The following is a description of a gene set: species: Homo sapiens Human Gene Set: GOBP_POSITIVE_REGULATION_OF_IMMUNE_RESPONSE Any process that activates or increases the frequency, rate or extent of the immune response, the immunological reaction of an organism to an immunogenic stimulus., and this is the list of marker genes: PLCG1 (NCBI Gene Id 5335), KLRD1, PCK1, RELA (NCBI Gene Id 5970), IGHA2, FCGR1A, FLOT2, HSPA1A, GCSAM, USP27X, YWHAE, MATR3, IRF3, VTCN1, C1QC, CLPB, LAG3, C1QB, CD74, UNC93B1 (NCBI Gene Id 81622), PYDC1, RBCK1, KLRK1, TNIP2, ITPRIPL1, XIAP (NCBI Gene Id 8257), POLR3B, FCGR2B, GDI1, TGFB1, DHX33, TRIM3, FCN3 (ficolin 3), IL1B, GPR32P1, CCR7, BTN2A1, HCK (HCK proto-oncogene, Src family tyrosine kinase), ZP3 (NCBI Gene Id 7785), IPO5, CD300LD, IFNK, TRIL, LAMP1, CLEC7A, ANXA1, RAP1A, MALT1, CD1A, PDE4B, DHX58, MFHAS1, CD5L, CD80, TREX1, ARID5A, ALPK1, TLR8, MICB, CYBA, SIRT1 (sirtuin 1), CBLB, C4BPB, STK11, SASH3, UBASH3A, HMGB2, FPR1, LYPLAL1, PLA2G6, KCNK6, PHB1 (prohibitin 1), MSH2, IRF4, CD22, TIFA, PTPRC, STOML2, BANK1, MASP2, PLCG2, ZCCHC3, PRAM1, RAB11FIP2, KLRC4-KLRK1, UBR2, GATA3, GPR108, PRNP (prion protein (Kanno blood group)), IL23R, PPP6C, TRAT1, BAX, PTPN2, HLA-DOB, IL27RA, CD4, CD59, MIR200B, FGR, IGHG2, GPR33, HLA-C, FPR3, LGR4, SLAMF6, IGHE, CFP, NLRP10, CLEC6A, ZDHHC9, GRB2, BTN2A2, RAB29, C4B, FLOT1, IL1R1, HRG, IL17F (interleukin 17F), DAB2IP, POLR3G, CD300LF, FBXL2, CCDC134, TRIM5, MAP3K7, TRIM31, SRC, TRIM41, TRAF2, GPR32, TEC, CRKL, ZDHHC5, PUM2, CPTP, B2M, C8A, TRIM6, ZDHHC4, SMPDL3A, FYB2 (FYN binding protein 2), SHB, PJA2 (NCBI Gene Id 9867), IL12B, FBXO38, PRKCE, RABGEF1, TRGC1, IRAK4 (NCBI Gene Id 95458), TLR6, NINJ1, PYDC2, HLA-H, C6, PTPN22, TSPAN6, KCNK13, BRD4, ABHD8, TIFAB, PTPN6, PSEN1, EIF2B1, NLRC3, ERBIN, BTK, WNK1, SPI1 (NCBI Gene Id 6688), LAPTM5, LETMD1, OPA1, BLK, HLA-DQB1, CREBBP, NAGLU, CD38, WDFY1, HSP90AA1, NONO (non-POU domain containing octamer binding), OAS3, AZGP1, FOXP3, IGHG4, NCKAP1L, PAK3, NOD1, C5AR1, MLH1, EIF2B2, RNF39, HLA-E, XCL1, VAV3, EIF2B5, FCHO1, PAWR, RBM47, NLRP3, TRBC1, APPL2, F2RL1, MAPK8, USP15, HRAS, HLA-DPB1, KMT5C, PYHIN1 (NCBI Gene Id 149628), PELI1, TLR7, BPIFB1, AKT1, RNF31, FCER1G, ACOD1, IGKC, BTNL3, STING1, SLC15A2, SLC39A6, NOP53, BTNL2, EXOSC6, LAX1, IGLC6, SKAP1, MEF2C, RC3H2, CTSG, MIR17, EP300, C4A, SHLD1, SCIMP, IGHA1, BTN3A2, TICAM2, SHLD3, LRCH4, AARS2, IFNL2, EREG, HLA-F, NLRC5, HMSD, RAET1G, TREML4, PSPC1, MIR4691 (NCBI Gene Id 100616403), POLR3F, GPLD1, KRT1, STAT5B, EIF2AK4, GRAMD4, CR1L, TARBP2, DDX60 (NCBI Gene Id 55601), TKFC, APPL1 (NCBI Gene Id 26060), RC3H1, THEMIS2, PLD2, SERPING1, SLC19A1, USP17L2, AP1G1, S100A8, TRGC2, RNF135, MARCHF5, A2M, ZBP1, ZC3H12A, MS4A1, CD1E, BIRC3, HHLA2, CD46, IKBKE, PIK3R1, BMX, KAT5, UBE2N, TIRAP, MIR149, MIR146A, OTUD4, IL12RB1, HLA-A, CACTIN, UFD1, CMKLR1, NFAM1, SLC11A1, C3AR1, FOSL2, IRAK2, PRKD2, KLRC4 (killer cell lectin like receptor C4), C2 (NCBI Gene Id 12263), LAMP2, CYRIB (NCBI Gene Id 51571), RIPK2, NOS2, FCER2, COLEC12, MYD88, RAET1L, TAP2, RBM14, NCR3, GBP1, RPS19, USP29, SLC39A10, PLEKHA1, TNFSF13, KARS1, BTN3A3, TLR3, JAK2, ADAM8, CD79B, CD8A, S100A9, CTSS, SLC22A13, HPX, TLR1, NFKBIL1, CD3G (NCBI Gene Id 917), CACNB3, HSPD1, CARD8, IFNL4, ADA (NCBI Gene Id 100), PTPRS, PPT1, BCL2, TAX1BP1, HDAC6, NLRP6, SEC14L1, ABHD17A, PARK7, LCK (NCBI Gene Id 95387), PTPRJ, RNF125, FYB1, HSPA8, HLA-B, LILRA4, LBP, PRKDC, PHPT1, CD1B, RASGRP4, NAIP, FFAR2, RNF185, MAPK1, CCL5, SQSTM1, IL17A, IL15, MNDA, TOMM70, TYK2, INPP5D, NOD2, CFH, ULBP3, ANKRD17, CASP6, UBE2K, MR1, IDO1, NLRC4, TNFSF4, CLNK, LIPA, PARP1, SLC46A2, PDPK1, CCR2, MASP1, TRBC2, HLA-DMA, IGLC7, ARRB2, MIR136, LGALS3, LIME1, CD1D, YES1, CD47, IFNL1, MIR18A, PRKCQ, CD300LB, RIGI, TRIM65, RNF34, DHX9, IFNG, LILRB4, PRKCB, HLA-DQA2, MMP12, NLRP2B, SYK, BTN1A1, S100A14, TMIGD3, PYCARD, COLEC10, CD79A, XBP1, NSD2 (NCBI Gene Id 7468), IRF7, STAP1, C3, BRAF (NCBI Gene Id 673), MIR21, C5AR2, RPS6KA3, IGHD, ELP6, C17orf99, CYLD, TRIM15, GPR65, CLU, ZNF683, CD8B, PCBP2, MIR140, IGLC3 (NCBI Gene Id 3539), LY96, REG3G, CARD11, MIR520E (microRNA 520e), C1R, ITGB2, GPS2, POLR3C (NCBI Gene Id 10623), LILRA2, PIK3CA, CFD, CASP1, NFKBIZ, GPATCH3, TXK, RTN4, MBL2, STMP1, TRDC, MAVS, TICAM1, UBQLN1, APP, FCMR, GPR31 (NCBI Gene Id 2853), PHB2, HMGB1, IL18RAP, SH2D1A, PQBP1, KLRC3, AP3B1, IL4R, IL2, ITCH, GBP2, TLR2, ULBP1, PLCL2, IL10, FZD5, PVRIG, TYRO3, CD55, ITK (IL2 inducible T cell kinase), TNFAIP3, C4BPA, HCFC2, SIN3A (NCBI Gene Id 25942), HLA-DQB2, ZNRF4, TRAF6, MARK4, ZDHHC18, LACC1, C8G, IL18R1, SUSD4, NAGK, RARA, WNT5A, TREM2 (triggering receptor expressed on myeloid cells 2), CD36, CFB, HEXIM1, NR1H4, TRAF3IP3, KLHL6, KLK7, INAVA, TESPA1, TNIP3, HAVCR2, CSK, MAD2L2, TLR9, EIF2B3, PLA2G4A, TBX21, ELF1, DENND1B, IFNL3, ESR1, C5, BAG6, NLRP1, LRRC14, CD3E, IL4, LRRC19, IL23A, C9, LAT2, RASGRP1, CD1C, TRIM32, SFPQ, ZNFX1, TNIP1, C8B, EIF2B4, HMCES, TLR5, MIR200C, CFHR1, IGHM, FCN1, TRIM56, EPG5, NR4A3, IFI16, CFI, SECTM1, USP50, PLPP4, SLC15A4, MEFV, TFRC, MIR210, MIR19A, CR2, PTK2, IL6ST, IGLC1, MIR708, TAB1, RNF144A, CD40, GSDME, AIM2, NR1D1, HSP90B1, LTA, HLA-DOA, ZDHHC3, HSPA1B, STX4, SPHK2, DDX3X, PIK3AP1 (NCBI Gene Id 118788), KLK3, ULBP2, CLCF1, HLA-G, LPXN, MED1 (mediator complex subunit 1), CAV1, SPSB3, ZDHHC1, PVR, ATAD5, LATS1, IL18, BTNL8, TASL, MIR520B, IRAK1, IKBKB, CGAS (NCBI Gene Id 115004), HLA-DRB1, LAT, MAPKAPK3, KIR2DS2, IRAK3, PAK2, IFI35, THY1 (Thy-1 cell surface antigen), FCN2, AKIRIN2, STAT5A (signal transducer and activator of transcription 5A), SHLD2, MIR34A, PRKD1, CD7, PGC, IL21, CD14, RAB7B, KCNN4, CFHR4, LCP2, RNF115, BTRC, KLRC1, HLA-DPA1, BTN3A1, TGFB2 (transforming growth factor beta 2), ELANE, BTNL10P, KLK5, ICOSLG, ABL1, IRF5, TRAC, NMI, DUSP3, YWHAG, FYN, BRCC3, RGCC, MOG, ZNRF1, BANF1, TBK1, STAT6, HLA-DRB5, CD81, RFTN1, CTLA4, COLEC11, SOCS5, LGALS9, CFHR3, OGT (NCBI Gene Id 8473), PRKAA1, CD226, IL33, PYDC5, TNFSF13B, CD86, TRIM11, PRKCD, SPG21, FPR2, NPLOC4, IFNB1, DDX41, CD28, BIRC2 (baculoviral IAP repeat containing 2), KCNJ8, C1QA, LIMK1, TMEM126A, BCL10, PRKCZ, TRAF3, CPT1A, IKBKG, NR1H3, GBP5, MAP2K6, CRTAM, C1S (NCBI Gene Id 716), DUSP22, C1RL, XRCC5, POLR3D, MIR20A, ZP4, MYO1G, CD3D, NFATC2, SH2B2, BRD2, HLA-DRB3, NECTIN2, ZBTB1, PLA2G1B, OTULIN, PLSCR1, CD177, EXOSC3, ERMAP, RPS3, IGHG3, IL12A, CHUK, LYN, PUM1, SPPL3, SIRT2, NLRX1, GCSAML, SCARA3, NFKBIA, NCK1, ZC3HAV1, TP53BP1 (tumor protein p53 binding protein 1), CFHR2, PLA2G5, TRIM62, CD19, DGKZ, RSAD2, SH2D1B, RNF170, OASL, TLR4, DDRGK1, CACNB4, ITGAM, IGHG1, SIVA1, MAPKAPK2, HLA-DQA1, TNF, CADM1, GFI1, P2RX7, RAET1E, FOXP1, IL6, NFKB1, SARM1, C7, IFIH1, PAK1, LILRB1, PIK3CD, ZDHHC12, TYROBP, AURKB, CD160, VSIG4, FCRL3, CD300A, HLA-DRB4, CMTM3, SLC15A3, RIF1, TLR10, LTF, KIR2DL4, THEMIS, KLRC2, NFKBID, EIF2AK2, PPP2CA, SMPDL3B, STX7, CFHR5, CR1, LATS2, KLHL22, PRKCH, CARD9, CLEC4E, GPR151, PARP9, CD276, BCAR1, VAV2, EZR, HLA-DRA, CD72, PMS2, ZAP70, NEK7, CD2AP, VAV1, CD247, XRCC6, BECN1, CD274, SLA2, FADD, TNFRSF21, ECSIT, KMT5B, HLA-DMB, CSNK1A1, BLNK, SLAMF1, HLX, GKN2, TRIM25, C1QBP, ATAT1, OAS1, KHDRBS1, FOSL1, BTNL9, SOS1, WASHC4, CEACAM1, PDE4D, PAXIP1, LSM14A, IRGM, CCL19 (C-C motif chemokine ligand 19), RIOK3, IRF1 (NCBI Gene Id 96501), BTN2A3P